The following is a description of a gene set: species: Homo sapiens Monoamine GPCRs Human Gene Set: WP_MONOAMINE_GPCRS, and this is the list of marker genes: ADRA2C, ADRB3, HTR2A (NCBI Gene Id 3356), CHRM5, DRD3 (dopamine receptor D3), HTR4, CHRM4, HTR1D, HRH2, ADRA2B (NCBI Gene Id 151), CHRM1, DRD5, CHRM3, HTR1F, ADRB2, ADRB1, CHRM2, DRD1, DRD2, DRD4, HTR6, ADRA1B, ADRA2A, HRH1, HTR1A, HTR7 (5-hydroxytryptamine receptor 7), HTR1E, HTR2C, HTR1B, ADRA1D (adrenoceptor alpha 1D), ADRA1A, HTR5A, HTR2B